The following is a description of a gene set: Disturbance of facial expression studied in species Homo sapiens Human Gene Set: HP_DISTURBANCE_OF_FACIAL_EXPRESSION An abnormality of the gestures or movements executed with the facial muscles with which emotions such as fear, joy, sadness, surprise, and disgust can be expressed., and this is the list of marker genes: NECTIN1, SCN1A, EP300, GLI3, PLPBP, PLA2G6, SCN2A, MTMR14, SCN9A, TP63, PNPT1, DNM2, ATP1A2, PANK2, GABRA1, GABRG2, IRF6, LRIG2, ALDH7A1, KCNQ3, SCN1B, PDE2A, CREBBP, ATXN8OS, PNKD, CP, MECP2, MSX1, TTR, ENSG00000288330, PMP22, CACNA1A, KCNQ2, PCDH19, GATAD2B, PRRT2